Given this list of marker genes Fgf9, Fgf8, Kl, Fgf20, Fgf3, Fgf5, Fgf10, Fgf22, Fgf2, Fgf4, Fgfr1, Fgf6, Plcg1, Fgf1, Fgf17, Fgf23, here is a description of the gene set: Phospholipase C-mediated cascade: FGFR1 Mouse Gene Set: REACTOME_PHOSPHOLIPASE_C_MEDIATED_CASCADE_FGFR1 studied in species Mus musculus